The following is a description of a gene set: In one model of Vpr mediated induction of apoptosis, Vpr acts directly on the mitochondrial permeability transition pore complex through its interaction with adenine nucleotide translocator (ANT). This interaction promotes the permeabiliztion of the mitochondrial membranes resulting in the release of cytochrome c and apoptosis-inducing factors. Reactome Pathway: Vpr-mediated induction of apoptosis by mitochondrial outer membrane permeabilization part of: Interactions of Vpr with host cellular proteins studied in species Homo sapiens, and this is the list of marker genes: SLC25A6, vpr, SLC25A5, SLC25A4